Given this list of marker genes Pcp4, Dyrk1a, Nefh, Cldn11, Nefm, Shank2, Ina, Ldlrap1, Nrp1, Htr2a, Prph, Nefl, Dmd, here is a description of the gene set: Mouse Gene Set: GOCC_NEUROFILAMENT studied in species Mus musculus A type of intermediate filament found in the core of neuronal axons. Neurofilaments are heteropolymers composed of three type IV polypeptides: NF-L, NF-M, and NF-H (for low, middle, and high molecular weight). Neurofilaments are responsible for the radial growth of an axon and determine axonal diameter.